The following is a description of a gene set: species: Mus musculus The chemical reactions and pathways involving threonine (2-amino-3-hydroxybutyric acid), a polar, uncharged, essential amino acid found in peptide linkage in proteins. Mouse Gene Set: GOBP_THREONINE_METABOLIC_PROCESS, and this is the list of marker genes: Gcat, Tha1, Tdh, Thnsl2, Phgdh